The following is a description of a gene set: Mouse Gene Set: GOBP_POSITIVE_REGULATION_OF_CELL_PROJECTION_ORGANIZATION studied in species Mus musculus Any process that activates or increases the frequency, rate or extent of the process involved in the formation, arrangement of constituent parts, or disassembly of cell projections., and this is the list of marker genes: Itga6, Arpc2, Adcyap1, Wnt5a, Plxnc1, Qki, Anln, Parp6 (poly (ADP-ribose) polymerase family, member 6), Gm14137, Hap1, Elavl4, Hdac6, Fes, Lrp1, Wrap73, Arhgap32, Rab11fip3, Map3k13, Cux1, Gpc2 (NCBI Gene Id 71951), Megf8, Ndel1, Stk11, Dvl3, Dmd, Abl2, Def8, Il1rapl1, Ppp2r5d, Plekhm1, Epo, Iqgap1, Grip1, Smurf1, Rufy3, Wls, Enpp2, Itpr1, Braf, Ep300, Robo2, Rab21, Clip1, Ins2, Wnt3, Scarb2, Hspa5, Ppp1r35, Atmin, Ptpn5, Ift20, Ptprz1, Fbxo38, Abl1, Shox2, Trim67, Ccl21a, Vil1, Vegfa, Tubb2b, Pafah1b1, Gprc5b, Dnm1l, Itga3 (integrin alpha 3), Cul7, Bmp7, Golga2, Disc1, Rnd2, Ppp1r9a, Mapt, Pias2, Adnp, Bmp4, Nedd9, Khdc3, Mark4, Fbxo31, Kat2b, Prkci, Zfyve27, Plxnd1, Kdm1a, Fyn, Nlgn1, Dynlt1f, Dcx, Alkal1, Rac2 (NCBI Gene Id 19354), Ntrk1, Ret, Rgs2, Coro1c, Alkal2, Caprin1, Nck1, Gpm6a, Kit, Alk, Coro1b, Magi2 (membrane associated guanylate kinase, WW and PDZ domain containing 2), Ccl21b, Myo3a, Saxo1, Tiam1, Adam17, Sema7a, Ccl21d, Rapgef1, Ltk, Nf1, Tgfbr1, Mir124a-3, Dpysl3, Tapt1, Rgma (NCBI Gene Id 244058), Abi2 (abl interactor 2), Apoe, Hras, Wasf2, Ccl21e, Caprin2, Kif3c, Clrn1, Fgfr1, P2ry12, Cnr1, Nckap1, Eps8l1, Bmpr2, Atp8a2, Prkd1, Mien1, Zdhhc15, Obsl1, Adamts1, Map2k2, Tnn, Cx3cl1, Gsk3b, Epor, Ccr7, Nme2, Cenpj, Myo5b, Kctd17, Bhlhb9, Apbb1, Cask, Dynlt1b, Dlg4, Ankrd27, Lpar3, Ccl19, Trpc5 (transient receptor potential cation channel, subfamily C, member 5), Mfn2, Cfl1, Ntrk2 (NCBI Gene Id 77471), Nrg1, Carmil1, Itgb1 (NCBI Gene Id 70812), Fmr1, Grn, Prkcq, Nckipsd, Pqbp1, Eps8l2, Ripor2, Ttbk2, Cxcl12, Neu1, Agt, Islr2, Mstn, Efemp1, Wasl, Pou4f2, Fuz, Fez1, Entr1, Bmp5, Mir124a-2, Rpl4, Crp, Auts2, Ccp110, Plxnb1, Stau2, Cdc42ep2, Wnt1, Dixdc1, Cep120, Met, Plk5, Ptprf, Ptk6, Gdi1, Dnm3, Sirt1, Wnt3a (wingless-type MMTV integration site family, member 3A), Camk1d, Scn1b, Atp1b2, Eif2b2, Tnfrsf12a, Anapc2, Nptn, Ndrg4, Rp1, Ptk7, Plppr5, Crocc, Serpini1, Eps8l3, Snx3, Hgf, Pla2g3 (phospholipase A2, group III), Camk2b, Actr2, Stmn2, Epha4, Hsp90aa1, Rap1a, Fn1, Htt, Ddr1, Espn, Ift88, Flna, Mfn1, Ppp2r5b, Sgk1, Tmem67 (NCBI Gene Id 76678), Ilk, Pcp4, Brk1, Tenm3, Arsb, Akirin1, Lrrc7, Mtor, Epha3, Rit2, Ptn, Arap1, Twf1 (twinfilin actin binding protein 1), Nin, Limk1, Dbn1, F2rl1 (F2R like trypsin receptor 1), Retreg3, Ss18l1, Rac1, Numb, Dcc, Ephb2, Kalrn, Cdc42ep3, Fxn, Trpv2, P3h1, Plek2, Zeb2, Palm, Reln, Zmynd10, Pfn1, Prom2, Cep135, Nrp1, Pacsin1, Arhgap35, Prl2c2, Bcl11a, Mob2, Ryk, Slc30a1, Fam98a, Styxl1, Carmil2, Frmd7, Dynlt1a, Fkbp1b, Tenm2 (NCBI Gene Id 77515), Dvl2 (dishevelled segment polarity protein 2), Ngf, Fzd4, Pik3r1, Twf2, Mir124a-1, Golga4, Map2k1, Dvl1, Cpeb1, Ccdc88a, Afdn, Hdac4, Ngfr, Tmem30a, Marcks, Amigo1, Robo3 (roundabout guidance receptor 3), Bdnf, Ahi1, Kat2a, Ap2a1, Cyfip1, Zfp804a (zinc finger protein 804A), Atf1, Nme1, Pak1 (NCBI Gene Id 18482), Ikbkb (inhibitor of kappaB kinase beta), Rala, Cbfa2t2, Atp7a, Efna5, Eif4g2, Xlr3b, Dab2ip, Cdh4 (cadherin 4), Eps8, Rab3ip, Cflar, Negr1, Ndnf, Acsl6, Stk24, Ntrk3, Dynlt1c, Ddx56, Dock11, Cntf, Ache, Sema5a, Stk25, Neurl1a, Cdc42ep4, Creb3l2, Fzd1, Pak3, Bbs4, Macf1, Hnrnpk, Itga2, Cobl, Sema4d, Tbc1d24, Map1b, Tiam2, Plce1, Dzip1, Fscn1, Rapgef2, Srf, Akap5, Nrxn1, Htr7, Ankrd1, Lyn, Grin1, Ranbp1, Sf3a2, Ptk2b (NCBI Gene Id 211703), Katnb1, Ube2v2, Ptbp1, Lcn2, Tox, Dynll1, Avil, Enc1, Scarf1, Myo3b, Rab8b, Apc (NCBI Gene Id 11789), Aqp1, Nrdc, Nfe2l2, Baiap2, Ezh2, Tgfb3, Picalm, Chodl, Itpka, Il6, Metrn, Hspb1, Snap91, Agrn, Fbxw8 (NCBI Gene Id 75791), Arf6, Crabp2, Ntn1, Ehd1, Plxnb3, Trak1, Nox1, Cdc42ep1, Tmem106b, Shoc2, Pum2, P2rx7, Washc5, Dhx36, Eef2k, Cntn1, Vldlr, Plxnb2, Setx, Dnm2, P2ry2, Cd24a, Igf1r, S100a9, Cdkl5, Ptprd, Opa1, Cxcl5, Actr3, Fig4, Fnbp1l, Lrp8, Tsc2, Cdc42ep5, Ccl21f, Ddr2, Map6, Sh3glb1, Crtc1, Serpinf1, Cdkl3, Fut9, Dbnl, Tnik, Camk1 (NCBI Gene Id 52163), Adcy10, Tenm1, Rrn3, Dscam, Slitrk1, Rreb1, Mark2, Robo1, L1cam, Sphk1, Atoh7, Shtn1, Kidins220, Skil, Ins1, Septin9, Src, Cdc42, Mdk, Zmynd8, Nefl, Mns1, Lrp6, Ist1, Numbl, Cux2, Lif, Rhoq, Serpine2